Given this list of marker genes FGG, HRG, F11, CTSH, ARF4, HTRA1, TIMP1, APOA1, CPB2, APOC3, ADAM9, FGA, TF, ANG, CSRP1, F2, PF4, MMP9, GNG12, C8A, CTSO, C8G, MMP2, CLU, FBN1, KLKB1, LAMP2, LTA4H, MEP1A, ACOX2, C1S, S100A1, F10, C9, LEFTY2, USP11, S100A13, PRSS23, PLEK, HPN, MMP15, SH2B2, ANXA1, MMP8, F9, MMP14, ITGB3, CTSE, C3, CAPN2, F3, GSN, PROS1, F8, C2, CD9, PLAU, C1R, MMP3, GDA, APOC1, TFPI2, RGN, HNF4A, CPN1, PROZ, MMP1, BMP1, F2RL2, CFH, CTSB, ITGA2, F13B, THBD, PDGFB, CFD, MBL2, CASP9, VWF, RAPGEF3, FURIN, CFB (NCBI Gene Id 629), LGMN (legumain), MSRB2, CRIP2, MASP2, COMP, SIRT2, KLK8, WDR1, TIMP3, CAPN5, DPP4, A2M, ITIH1, THBS1, DCT, ISCU, C8B, PLAT, RABIF, CFI, PLG, HMGCS2, C1QA, APOC2, CTSK, RAC1, MMP10, DUSP6, SERPINB2, FN1, MAFF, MST1, PROC, GP9, FYN, F12, PREP, SPARC, DUSP14, GP1BA, GNB2, CPQ (carboxypeptidase Q), PEF1, SERPINE1, SERPING1, MMP11 (NCBI Gene Id 4320), KLF7, LRP1, OLR1, SERPINA1, MMP7, CTSV, PECAM1, TMPRSS6, SERPINC1 (serpin family C member 1), P2RY1, here is a description of the gene set: studied in species Homo sapiens Genes encoding components of blood coagulation system; also up-regulated in platelets. Human Gene Set: HALLMARK_COAGULATION from publication Liberzon A, Birger C, Thorvaldsdóttir H, Ghandi M, Mesirov JP, Tamayo P (PMID 26771021)